Given this list of marker genes SLC7A11, DCLK1, PHGDH, ABCA12 (ATP binding cassette subfamily A member 12), NELL2, ENSG00000278932, SERTAD2, SLC1A4, MFAP3L, SLC3A2, VEGFA, SLC7A5, MAP1B, IFRD1, HERPUD1, SDF2L1, TFF3, INHBE, ASNS, SEC24D, ASS1 (argininosuccinate synthase 1), BHLHE40, GADD45A, DNAJB9, LARP1B, DDIT3, RPRM, MID1, SESN2, IGF1, SFMBT2, PSPH, IGF2, PCDH8, GDF15, KRT81, EGR3, here is a description of the gene set: Human Gene Set: PACHER_TARGETS_OF_IGF1_AND_IGF2_UP Insulin-like growth factor (IGF) signaling is a key regulator of breast development and breast cancer. We have analyzed the expression of the IGF signaling cascade in 17 human breast cancer and 4 mammary epithelial cell lines. Five cell lines expressed high levels of IGF1 receptor, insulin (INS)/IGF receptor substrate 1, IGF-binding proteins 2 and 4, as well as the estrogen receptor (ESR), indicating a co-activation of IGF and ESR signaling. Next, we stably overexpressed IGF1 and IGF2 in MCF7 breast cancer cells, which did not affect their epithelial characteristics and the expression and localization of the epithelial marker genes E-cadherin and beta-catenin. Conversely, IGF1 and IGF2 overexpression potently increased cellular proliferation rates and the efficiency of tumor formation in mouse xenograft experiments, whereas the resistance to chemotherapeutic drugs such as taxol was unaltered. Expression profiling of overexpressing cells with whole-genome oligonucleotide microarrays revealed that genes were upregulated >2-fold by both IGF1 and IGF2, 9 by IGF1, and 9 by IGF2. Half of the genes found to be upregulated are involved in transport and biosynthesis of amino acids, including several amino acid transport proteins, argininosuccinate and asparagine synthetases, and methionyl-tRNA synthetase. Upregulation of these genes constitutes a novel mechanism apparently contributing to the stimulatory effects of IGF signaling on the global protein synthesis rate. We conclude that the induction of cell proliferation and tumor formation by long-term IGF stimulation may primarily be due to anabolic effects, in particular increased amino acid production and uptake. studied in species Homo sapiens from publication Pacher M, Seewald MJ, Mikula M, Oehler S, Mogg M, Vinatzer U, Eger A, Schweifer N, Varecka R, Sommergruber W, Mikulits W, Schreiber M (PMID 16774935) Genes up-regulated in MCF7 cells (breast cancer) by IGF1 and IGF2.